The following is a description of a gene set: The regulated release of cortisol, a steroid hormone that in humans is the major circulating hormone of the cortex, or outer layer, of the adrenal gland. studied in species Homo sapiens Human Gene Set: GOBP_CORTISOL_SECRETION, and this is the list of marker genes: GALR1, GAL, CRH, PTPN11, GHRL